Given this list of marker genes IFI35, TRA2A, TRAPPC9, ABCD3, OASL, RIGI, MGAM, ADGRE1 (NCBI Gene Id 2015), RGS13, HLA-DQB2, ALCAM, RNF10, ZFAND6, TNFSF8, SMS, CLEC2D, SSR4, MT1E, GRM8, MAP2K4, NRIP1, STX16, RPS12, SLC39A8, SERPING1, HDAC4 (NCBI Gene Id 9759), IKZF5, ADNP, CCDC91, U2AF2, CYBA (NCBI Gene Id 1535), CAPZA1, ADGRG3, N4BP1, ATP5PO, NAP1L1, FOLR1, TRA2B (transformer 2 beta homolog), CAPN3, SCNM1, HNRNPA1, PRUNE2, YWHAB (tyrosine 3-monooxygenase/tryptophan 5-monooxygenase activation protein beta), RHBDF2, JAG1, BTBD1, RBM22, CYB5R2, OTUB2, SLC19A2, NCOR1, EFCAB14, SMURF2 (SMAD specific E3 ubiquitin protein ligase 2), RPL7, LIG4, PPP2R5A, TMEM185B, DRG1, ARHGEF7, PTPRJ, RPL14, OAS1, WDR41, DNAJC15, ZNF292, GALC, PID1, CENPC, EPS15, SEMA4A, HIPK3, KLHDC2, TMCO1, AATF, PSMB8, RAB29, TAF12, TRGV5 (T cell receptor gamma variable 5), PIGA, IPO7, FGF4, PIGV, CCDC71, EAPP, LDHB, ECHDC3, ZNF696, APRT, FDFT1, FXR1, ARMC8, CBX1, JAK3, DLD, COQ8A, COPA, RPL23A, FKRP, CDK13, VTI1B, RER1, RPS9, RPL28, VAV1, TNFRSF1A, DNAAF1, HAL, PPM1D, MAP2K3, ST20, DPF2, IL1RN, CLUAP1, ENTPD1, RPS2, FAM13B, SMG8, NLRP1 (NLR family pyrin domain containing 1), PQBP1, LGALSL, ITM2B, EIF4ENIF1, ARID1A, PABPN1, TOR1AIP1, ZBTB24, ATP5PD, MAPK14, PHIP, BCLAF1, RNF115, CLK4, GLIPR1, DAPP1, LPAR6, GPR65, RPS26, CALM3, WDR47, SRSF9, IGLV4-60, ABHD5, SEC24A, ADNP2, CBFB, HOMER2, POLR1D, BUB1B, DENND1B, FCGR2A, MDM4, YY1, POLR1G, GRB2, TMBIM4, RNASE4, STAG3L4, CNBP, DDX60 (NCBI Gene Id 55601), EIF4G3, HK1, MADD, TMEM243, ZNF281, USP10, MTF2, EIF3G, TCP1, LPAR2, LDHA, DYNC1LI2, DNAJA1, ACTR3B, TBL3, CMC2, NFYA, SRRM1, RPL9, IMMT, F7, NGDN, PIK3R5, COX8A, LRRC47, WDR11, PLXNC1, PTPN22, RPL18, OSTM1, PLCB2 (NCBI Gene Id 5330), PIAS1, RSRC2, OLA1, POMZP3, NDUFS1, SETD2 (NCBI Gene Id 84184), CGGBP1, KIAA0586, AAMP, here is a description of the gene set: Th1 and Th2 cells arise from a common precursor cell in response to triggering through the TCR and cytokine receptors for IL-12 or IL-4. This leads to activation of complex signaling pathways, which are not known in detail. Disturbances in the balance between type 1 and type 2 responses can lead to certain immune-mediated diseases. Thus, it is important to understand how Th1 and Th2 cells are generated. To clarify the mechanisms as to how IL-12 and IL-4 induce Th1 and Th2 differentiation and how TGF-beta can inhibit this process, we have used oligonucleotide arrays to examine the early polarization of Th1 and Th2 cells in the presence and absence of TGF-beta after 0, 2, 6 and 48 hours of polarization. Human Gene Set: GSE2770_IL12_VS_TGFB_AND_IL12_TREATED_ACT_CD4_TCELL_6H_DN from publication Lund R, Aittokallio T, Nevalainen O, Lahesmaa R (PMID 14607935) species: Homo sapiens Genes down-regulated in CD4 T cells activated by anti-CD3 and anti-CD28: IL-12 (6h) versus TGFB1 and IL-12 (6h).